The following is a description of a gene set: Human Gene Set: HE_LIM_SUN_FETAL_LUNG_C2_CYCLING_DC_CELL studied in species Homo sapiens from publication He P, Lim K, Sun D, Pett JP, Jeng Q, Polanski K, Dong Z, Bolt L, Richardson L, Mamanova L, Dabrowska M, Wilbrey-Clark A, Madissoon E, Tuong ZK, Dann E, Suo C, Goh I, Yoshida M, Nikolić MZ, Janes SM, He X, Barker RA, Teichmann SA, Marioni JC, Meyer KB, Rawlins EL (PMID 36493756) Cycling DC, and this is the list of marker genes: GOT2, PSMG3, CEP41, CEP192 (centrosomal protein 192), SLC27A5, RAD17, ZNF738 (NCBI Gene Id 148203), DPH7, MTFR2, ECHDC2, ZDHHC16, CYREN (cell cycle regulator of NHEJ), SAP30, DLGAP5, NUP85, MACROH2A2, SNHG30, PSMD10, TRMT13, TXNL4B, PRIMPOL, ECT2, GPX7, PMM1, NTAQ1, SCAPER, PYROXD1, UQCC4, POLA1, HAUS6, CDC6, LMNB1, CENPA, NKG7, KCTD17, LRRC47, ADGRG5, C6orf136, USP14, TNFAIP8L1, PRELID3B, TFPT, H2AC13, PABPC1L, PDZD11, RAD1, PCIF1, RUVBL1, KIF20B, TP53I13, C15orf61, CCNB2, CSTF1, NTMT1, ATRIP, STK26, FAM111B, RCCD1 (RCC1 domain containing 1), CISD1, CDCA3, ITGB3BP, TSEN15, TIMM29, MRRF, ERI3 (ERI1 exoribonuclease family member 3), DCAF15, DCPS, GSTM1, PSMD14, CENPU, LAPTM4B, SLC25A24, SUPT3H, MRE11, LRRC40, WDR41, CFAP298, POLR2D, USP13, RCAN3, GATB, TROAP, MLST8, DLD (dihydrolipoamide dehydrogenase), PREB, CD2BP2, ALDH7A1, SMYD2, NIP7, DNAJC21, BRCA2, CBFB, GEMIN6, IGF2BP1, CARHSP1, MBIP, RASSF7, PDLIM1, GMDS, GXYLT1, PCGF6, PRMT3, GMNN, MCM10, AIFM1, EXOSC2, MIX23, CTPS1, NSMCE4A, POC5, E2F8, BUB1, CDC20, LINC01150, SEC24B, TAF5, TRAIP, SLC41A2, TP53BP2, SCRN1, CRAT, ERG28, FAM72B, CEP57L1, C2orf69, CENPO, APOBEC3B, RAD51C, CDKAL1, ZNF85, REC8, CEP83, SRD5A3, AARS2, DHRS13, AGPS, SLC16A7 (solute carrier family 16 member 7), CHRAC1, TRMT6, EFNB1, INTS9, ST3GAL3, HIRIP3, UQCC1, CLPB, PDE7A, NUP88, H3C15, TSEN54, PSPC1, POLD3, TST, BOLA3, SDHAF3, TMEM156, MTA1, CIP2A, GLRX5, PAIP1, TRIT1, PGM2, TMEM38B, MRPL39, METTL4, PDF, POLA2, E2F2, WRAP73, RMI2, UQCC3 (ubiquinol-cytochrome c reductase complex assembly factor 3, NCBI Gene Id 790955), SLC5A6, NABP2, ALG5 (NCBI Gene Id 29880), ZNF143, DDB2, AK6, ZNF90, SACS, SIGMAR1, GTF2H2C, TIMELESS, NIF3L1, FANCM, PKP4, NOC2L, C1orf122, NDUFA9, TMEM203, RLIG1, BSCL2, GAPT, TAF6, HYI, CLN6, BCL7A, PRIM2, NIBAN1, ISOC2, THAP7, HELLS, PRELID2, PAQR4, SKA2, EBNA1BP2, GNB5, PARP2, ANKRD28, TIFAB, MUTYH, UBR7, ZCCHC8, TAF6L, TTF1, LAS1L, PIMREG, CENPC, PDS5B, DYNC2I2, ECSIT, SENP5, PPIL1, TPX2, DHRS4L2, DEPDC1, EDC4, FZD2 (NCBI Gene Id 2535), TSFM, CCP110, CETN2, H2AC21, RRM1, PSMG4, TCF19, ZNF668, PHAX, MSH3, MGAT2, DLST (NCBI Gene Id 1743), SEL1L3, TOP3A, MTERF3, MNAT1, ACAT1, PPP5C, NDC80, CCDC86, ZWINT, ACBD6, RHBDD2, MBOAT2, ASF1A, PCK2, H3C14, MRPL2, DSCC1, CDC23, BUD13, CSTF3, TTF2, SNAPC5, NUP133, APOO, SLC35B2, BEND5, FILIP1L, PSMC3IP (NCBI Gene Id 51769), PLK1, FUNDC1, IRF4, ANLN, EMC9, C1orf174, RUNX2, WDR83, RUVBL2, ESCO2, YAF2, ALDH18A1, CEP131, RPP30, SLC25A1, OGFOD3, WDR18, LRRC45, HMMR, DLAT, RMI1, IPO9, UBE2S, CSTF2, FEN1, CLK2, TOMM40L, MYCBP, SEPTIN1, TMA16, RARS1, SEH1L, BABAM2, SPOUT1, ALCAM, SUV39H1, TMED1, GMPS, MARVELD1, POLD2, SPC24, HARS1, PRPSAP1, UHRF1, EEF1E1, CHST2, TRIM11, NCAPG, ARHGAP11A, IMMP1L, ATAD2, PRC1, CXXC1, RAD51D, HAT1, ZW10, RCC1, NUDCD1, SPRTN, DCAKD (dephospho-CoA kinase domain containing), NUP93, ENOPH1, ACAT2, UTP4, MRPS27, SLC39A8, RAD18, ZNF503, ASXL1, GALM, PMS2, MED20, PFKP, SPC25, MYL6B, MSH2, PKMYT1, ACOT2, INTS10, AUNIP, RFC1, HAUS3, IMPA2, PLRG1, MCOLN2, MRPS9, NEMP1, CD1C, MND1, LYAR, ORC2, CUL3, DIAPH3, KATNA1, AHI1, TRNT1, HENMT1, C12orf75, HPS6, DBF4, B3GNTL1, NRM, SNCA, MMAB, DERA, G2E3, CDC26, H2AC14 (H2A clustered histone 14), CNOT11, PARPBP, NPM3, WWOX, SRPK1, TUBG1, PCBD2, NNT-AS1, ASTE1, RMDN1 (regulator of microtubule dynamics 1), PTPN7, C1orf35, EXOSC10 (exosome component 10), CDCA7, CDCA2, SHMT1, UCK1, ZNF367, IFT22 (NCBI Gene Id 64792), WBP4 (WW domain binding protein 4), PITPNA-AS1, PPIE, CCR2, HAAO, PCLAF, SFXN4, FAM83D, NPRL2, SNAPC1, MCCC1, EBP, SARS2, KMT5C, TRAPPC13, PRPS1, NME1, CCDC18, CTNNAL1, PIDD1, RCAN1, PKIG, NTHL1 (nth like DNA glycosylase 1), RIOK1 (RIO kinase 1), MAGOHB, CYB561D2, KRR1, KCNMB1, UPF3B, H2AX, MED30, SARNP, DDX11, SCFD2, IER3IP1, ALYREF, XPO7, HMOX2, MAIP1, IGFBP7, INSR, EFL1, ACOX3, LETM1, STX18, CDT1, IPO13, TMEM102, CDC25C, XRCC1, RAVER1, TFB1M, MIS12, FAM72C, TEDC2, KMO, GLRX2, POLE2, NUDT15, CCDC34, CD7, FANCI, TEDC1, ACP3, THOC3, EHBP1, IDH3A, TAF9B, KLHDC4, EPB41L2, SAAL1, TIMM50, FH, AIRIM, SCO2, SCMH1, MCM2, INTS7, BANK1, MARS1, POLR1E, TMEM222, TMEM68, ZNF76, GCDH, GRK6, OGG1, BCL2, MASTL, TTLL12, NET1, KIF18B, PEX3, SLC2A1, CPOX, NUP210, LRRC42, UBE2M, CDK5RAP1, OGFOD1, TRIM14, NR2C2AP, ERCC4, TK1, COPRS, CRELD2, NUCB2, PI4K2B, NSD2, SPATS2, NCAPH2, NOL11, SLC26A6, MTA3, NEIL3, CKAP5, ISOC1, TRMU, PGM1, SLC43A3, UBE2T, RAB22A, LLPH, MLH1, TIMM44, UBE2C, H2AC17, PSRC1, GTF2F2, VPS16, RCC1L, PIGX, CCNA2, NT5C3A, MRPS14, EXOSC7, HEATR6, SMC2, CD79B, THOP1, CDKN2AIP, ARL6IP6, RPIA, SKA1, GTPBP4, TBC1D7, ACSF2, CEP43, SUN2, ZUP1, FAHD2A, RNASEH2A, DLEU2, NUDT2, DTYMK, DSN1, TBL3, LIG1, TELO2, ZWILCH, EFNA4, PHGDH, H2BC4, KIF15, GART, FADS1, SPAG5, PAFAH1B3, H1-5, CEP295, HAUS1, CDK10, CCNE2 (cyclin E2), ING2, COQ7, ACTR1B, PGAP2, CENPJ, TRAF2, FOXM1 (forkhead box M1), CCDC28B, H2BC7, MZF1-AS1, MGME1, PSMG1, AASDH (NCBI Gene Id 132949), HMCES, SPNS3, TRNAU1AP, ANAPC15, CDK1 (NCBI Gene Id 983), RBBP8, ASPM, SPINT1, ST3GAL4, ACYP1, EXOSC1, SGO2, NAE1, IFI27L1, ENHO, FANCA, HRAS, ATP6V0E2, FADS2, ERGIC2, CDC25B, CMSS1, EEF1AKMT2, CETN3, GATD1, FARSB, NIT2, CCDC14, TMEM106C, MIS18A (NCBI Gene Id 89756), METTL1, RAP1GDS1, RRP1, NUP50, C4orf46, SMYD3, POP4, LRR1, CCNB1IP1, EIF2B3, TRMT10C, N4BP2, MRPL38, NDUFS1, SCCPDH, MCM6, INCENP, USP39, MKI67, CCHCR1, SLC19A1, ESPL1, COQ5, KLHL7, MATK, TFAP4, ABCB8, DNAJA3, PDCD7, PLK4, MRPS2, CD1E, DKC1, BTG3, MZT1, KIAA1586, CEP55, GNL2, GINS4, TMX2 (thioredoxin related transmembrane protein 2), SNAI1, THAP3, FAM111A, GOT1, LRRC14, GTF3C5, CEP15 (centrosomal protein 15), SPIB, NUP205, UTP3, ZNF296, SPDL1, HLTF, CCNQ, SULF2, NUF2, ALG1, GINS3, BOLA1, NEK2, ZC3H8, NDUFC2, CDCA7L, H2AC20, EIF1AD, NXT2, H4C6, PXMP2, HMBS, KIF11, PAK1IP1, CCNF, SMG9, PEX19, CDC27, FANCL, RCN2, GTPBP6, SSBP4, LIN54, ANKRD26, DDX50, MAP7D3, AP4M1, PWWP2A, PCYT2, POMZP3, RAMAC, AAAS, ADAP1, SFXN1, RAB34, GTF2E2, USB1, PDRG1, ZGRF1, NUSAP1, SLC25A40, MFSD5 (NCBI Gene Id 84975), AURKB, SUCLA2, EGLN2, PSPH, PCNT, ATAD3B, CHAF1A, EXOSC9, SAPCD2, GMEB1, SGO1, UMPS, TMEM9, RANGRF, H2BC11, TMEM209, HSPBP1, AGGF1, CCNK, C9orf40, DDX55, VSIG10, BDH1, CLEC11A, RP9, ORC3, BCL2L12, ERAL1, RABL6, TDP1, VPS26B, MAD2L1BP, SMN1, CMPK2, HMGB3, CDCA5, AKIP1, KNTC1, PRADC1, PRR11, COQ2, OXCT1, PAM16, WEE1, SMPD4, FOXRED1, ZC3HC1, RFC3, MAP4K1, CHD1L, GGH, YARS2, UTP11, COPG2, CLECL1P, TFDP1 (NCBI Gene Id 7027), EFCAB11, BLM, H3C2, H3C8, HYLS1, H3C3, H2AC16, SEPHS1, RNF34, IFRD2, TIPIN, FPGS, GTSE1, NELFCD, PPP2R1B, STIL, PNO1, YEATS4, SLC35B1, SMC6, ING3, MCM3, HDAC3, IFT52 (intraflagellar transport 52), DMAC2, INIP, CHCHD4, ATP23, RPL39L, TTK, SNX4, BIRC5, ARHGEF39, CCDC51, CYB5A, CHEK1, GPATCH4, RHNO1, BBS7, NAPSA, CPSF3, CDK2, CFAP119, FN3KRP, HJURP, BRPF1, BCAT2, CCSAP, MCRS1, AREG, GLMN, RHOH, CTU2 (cytosolic thiouridylase subunit 2), CWC27, CD69, DDX49, CALHM2, RNASE2, CKAP2L, C4orf33, CEP152, FBLN1, ZC3H18, FBXO5, ARMC6, SASS6, RABEP2, H3C10, SNUPN, MDFIC, TCTN3, SLC25A17, NCAPH, PRKAG1, TM7SF3, GEMIN2, CCNB1, EXOSC6, H2BC15, H2AC8, RAD51AP1, TRAF4, ARL13B, NVL, NEMP2, BARD1 (NCBI Gene Id 580), CENPF, ENOSF1, C11orf24, IPO5, SLC25A19, SHCBP1 (NCBI Gene Id 79801), CKS1B, PTTG1, CDC7, HAUS5, BNIP1, YARS1, ATIC, JPT2, BRI3BP, SLC1A4, TOP2A, KANSL2, GOLPH3L, DOHH, SMPD2 (sphingomyelin phosphodiesterase 2), C21orf58, TRAP1, PCID2, PELP1, SLC2A4RG, NCAPD3, PPAT, GTPBP3, MRPS10, SKA3, WARS2, EED, KIF4A, CNOT9 (NCBI Gene Id 9125), POLR3K, CENPK, TOPBP1, TP53, TIMM22, C8orf76, ATPAF1, DONSON, TAF1B, BRF2, MIR4435-2HG, PPM1D, CEP78, GEMIN5, STIM2, TMEM39B, PCNA, EPB41, SKP2, PUDP, AARS1, NUP188, RFC5, HBS1L, CDKN2AIPNL, INTS13, PHF19, CIT, MRPL58, CD101, PAAF1, ATAD3A, GCHFR, CENPP (centromere protein P), JMJD8 (NCBI Gene Id 64483, jumonji domain containing 8), GINS1, PAK4, POLD1 (NCBI Gene Id 5424), GPN1, FADD, OPN3, ACAD9, MRPL48, FANCB, ANKRD39, TEX30, ODF2, FBLN2, ARL4D, CIDEB, ALMS1, SVIP, TRIAP1, KIF23, TMEM220, PRKRA, HMGXB4, AURKA, POC1A (POC1 centriolar protein A), PHETA2, MACROD1 (NCBI Gene Id 28992), KNSTRN, GTF2H2, PRMT5, QRSL1, SEC22C (SEC22 homolog C, vesicle trafficking protein), MMS22L, GCSH, WDR4, HCCS, EZH2, CKAP2, NT5DC2, TMEM19, FAM72A, MAK16, POLQ, GAR1, ARL3, RPA1, UCHL5, RAC3, CRYBG1, PABIR2 (PABIR family member 2), CHTF18 (chromosome transmission fidelity factor 18), RPS6KA5, SIGLEC6, CDK16, HPF1, PMS1, VRK1, CENPW, VRK2, RIBC2, NUP54, DDX56, IARS1, DUSP12, GLT8D1, NCAPD2, SPTSSA, NFYB, TMEM97, FIRRM, APEX2, STAM, HTRA2, TGS1, ASH2L, SMC4, NMB, ALDH16A1, INAFM1, PBX3, ITGB7, SQLE, TSN, WDHD1, UBALD1, ACTR6, MPHOSPH9, SIGLEC5, TBL2 (NCBI Gene Id 27203), PGP, DDA1, GTPBP8, ZNF639, PLAA, NEDD1, MRPL42, KRI1 (KRI1 homolog), FLT3, MRPS31, MCM7 (minichromosome maintenance complex component 7), CHST14, AGA, SAC3D1, FBXO22, ATAD5, NCAPG2, H2BC9 (NCBI Gene Id 8345), LMNB2, LTV1, H4C4, FCER1A, ZNF326, NAA50, OIP5, EXOSC3, MOCS2, C12orf43, CCDC25, TMX4 (NCBI Gene Id 56255), TADA1, FBXO4, ANKRD54 (NCBI Gene Id 129138), UNG, MKRN2, NEFH, CYB5B, ASRGL1, H3C7, PLGRKT, EIPR1, NUDT8 (nudix hydrolase 8), MAP2K5, COQ4, ZNF92, S100B, CES1 (carboxylesterase 1), BCL7C (NCBI Gene Id 9274), C19orf48P, CNOT10, DEPDC1B, LIN52, MRPL46, NOA1, IL18, TTC4, RBFA, CDCA4, CDKN3, FAM76B (family with sequence similarity 76 member B), SLF1, RANGAP1, MYBL2, PPP1R14B, PAXBP1, FAF1, MRPS28, TNPO3, COQ9, PAICS, NSMCE2, TADA2A, ISY1, TBP, GPALPP1, TCOF1, UAP1, CHAF1B, HAUS2, PXMP4 (NCBI Gene Id 11264), WDR76, ACAA2, RRP1B, CFAP20, SNRNP25, MOB3B, SLC52A2, USP5, DNA2, PRPF4, CENPQ (centromere protein Q), HGH1, DPH2, H2AC4, EEF1AKMT1, ELF4, DARS2, ORC1, RNF26, ZNF138, HSPA13, POLR1G, GPSM2, BOP1, FTSJ1, PRR3, NCBP1, XRCC4, ADAM15, PDE4D, ICMT, PDSS2, ALG8, SLC25A16 (NCBI Gene Id 8034), QDPR, NRGN, ASF1B, F8A1, PIGF, RTCA, MCM4, TMEM71, COASY, ANKRD36B, KIF22, MDC1, MRTO4, RXYLT1, SLC29A1, NDUFAF6, CPSF4, ARHGAP33, LRRC23, TMEM60, FAM72D, AGK, YDJC, CBX5, CDC45, CSE1L, KIF2C, MICB, HACD1 (3-hydroxyacyl-CoA dehydratase 1), SAP130, VCPKMT, PURB, NOC4L, KIF14, NUP155, MSLN, HROB, PHTF1, DNAJC9, ARMC10, DCTPP1, CTSW, CYP51A1, SRP68, CD2, H2AC11, ZNF789, BORA, BRD7, ILVBL, PPP1R14A, ACOT7, THEM4, CHMP7, RNASEH1, MYO19, C17orf49, GPS2, RNGTT, HMGN4, ATF1 (activating transcription factor 1), SLC25A38, ANAPC10, ZNF10, RBL1, KIF20A, ANAPC2, MMS19, CDKN2D, DVL2, TBRG4, SLC41A3, MRGBP, PAF1, TIMM8A, RFK, IFT57, ZNF93, CIAO3, THAP11 (THAP domain containing 11), TERF1, KIFC1, RFC2, SLC38A1, FANCD2 (FA complementation group D2), MED21, TSTD1, VPS4A, GINS2, GFER, GSTZ1, MSH6, ADK, ESYT2, RRM2, MRPS22, CDK5, TOE1, KLHL22, RFC4, DHFR, GON7, RFWD3, MMUT, GALNT3, CDCA8, NDC1, MRM2, KCNE5, COL9A2, ZNF714, HDGFL2, GMPPA, CNTLN, MRM3, POP7, ZNF574, ACD, PDE12, PIGU, TOR1A, E2F1, SMC5, HDDC3, GSS, JADE1, BRIX1, RAD54L, PDSS1, CEP20, PKIB, FZR1, AUTS2, METTL17, CASP6, HAUS8, CENPM, SIRT6, EXOSC8, RPE, MKS1, LEO1, ERVK3-1, TPGS2, ZC3H3, TYMS, WDR54, PPP2R5D, CCDC167, ANAPC7, PGRMC1, EAF2, MTA2, METAP1, TUBGCP3, SDHAF4, HILPDA, MRPS11, VCF2 (VCP nuclear cofactor family member 2), TXNRD1, ELP6, B4GALT4, RAD54B, SMIM13, CHAC2, RECQL, CEP128, TOMM34, CHEK2, MELK, MAP3K20, FIGNL1, SRSF8, ST14, POLR3A, NAA40, SAE1, NCKIPSD, CIAPIN1, UCK2, TSR3, MCAT, ATL2, ABCB7, MAD2L1, HARS2, NUP37, C11orf98, MTRFR, MTHFD1, BUB1B, PPP1R8, HDGFL3, INTS14, BRCA1, DHTKD1, CLSPN, MALSU1, DPM1, CUL2, KEAP1, PRPS2, NUFIP1, MCM8, DTL, TIMM21, WRAP53, C1orf131, COPS7B, BCKDHA, STRADA, NUP153, RBM10, CUTC, GEN1, MTFP1, RUSC1, CENPE, UBL7-DT, CASP8AP2, CEP135, ACTL6A, IMMP2L, ZDHHC6, H2AC12, WDR5, ISG20L2, PRKAG2-AS1, ORC6, SLC17A9, SAR1A, MRPS18A, MXD3, NREP, SMIM19, SEPTIN11, TTC39C, TRIP13, HACD3, ECI1, PSMB8-AS1, CENPH, CYBRD1, CENPL, TFB2M, POLE, UPK3A, PAGR1, POLR2C, BRD8, SLC37A4, CENPN, KIF17, PNPT1, SLC16A1, E2F7, STAG1, GAS2L3, PM20D2, GMPPB, HNRNPLL, SRPRB, SPHK2, MDM1, LILRA1, KIF18A, GPN2, RACGAP1, ANKRD36, H2BC18, IQCB1, ACAP1, STK19, RECQL4, SP2, NOL10, KDM1A, CEP85, MAGEF1, COPS8, BAG2, PRIM1, FANCG, AP1G2, TSR1, PTCD3, BRCC3 (NCBI Gene Id 79184), SUZ12, NNT, GEMIN4, DERL3, CDK5RAP2, ZCCHC17, ELK1, KNL1, CC2D1A, NAA15, LRRCC1, NUP107, CHRFAM7A, EMSY